The following is a description of a gene set: Reactome Pathway: lorlatinib-resistant ALK mutants Lorlatinib is a third generation tyrosine kinase inhibitor with effectiveness against ALK and ROS rearranged cancers. This pathway describes ALK mutants that are resistant to inhibition by lorlatinib. studied in species Homo sapiens part of: Drug resistance of ALK mutants, and this is the list of marker genes: ALK